Given this list of marker genes CRY2, TERF2, NFIA, TOM1L2, ENDOV, N4BP2, here is a description of the gene set: DNA repair and replication genes down-regulated in melanoma patients who will relapse vs patients who will not. from publication Kauffmann A, Rosselli F, Lazar V, Winnepenninckx V, Mansuet-Lupo A, Dessen P, van den Oord JJ, Spatz A, Sarasin A (PMID 17891185) species: Homo sapiens Human Gene Set: KAUFFMANN_MELANOMA_RELAPSE_DN We have identified a gene-profile signature for human primary malignant melanoma associated with metastasis to distant sites and poor prognosis. We analyse the differential gene expression by looking at whole biological pathways rather than individual genes. Among the most significant pathways associated with progression to metastasis, we found the DNA replication (P=10(-14)) and the DNA repair pathways (P=10(-16)). We concentrated our analysis on DNA repair and found that genes of this category, among a list of genes, are associated with metastatic progression. These genes belong essentially to the pathways allowing recovery of stalled replication forks due to spontaneous blockage or induced DNA lesions. Because almost all these differentially expressed repair genes were overexpressed in primary tumors with bad prognosis, we speculate that primary melanoma cells that will metastasize try to replicate in a fast and error-free mode. In contrast to the progression from melanocytes to primary melanoma, genetic stability appears to be necessary for a melanoma cell to give rise to distant metastasis. This overexpression of repair genes explains nicely the extraordinary resistance of metastatic melanoma to chemo- and radio-therapy. Our results may open a new avenue for the discovery of drugs active on human metastatic melanoma.